Given this list of marker genes IL4I1, THAP4 (NCBI Gene Id 51078), ATP7A, HGD, TAT, HPD, SLC45A2 (NCBI Gene Id 51151), TTC36, IYD, FAH, DCT, TYR, PCBD1, GSTZ1, TH, PAH, OCA2, here is a description of the gene set: Human Gene Set: GOBP_TYROSINE_METABOLIC_PROCESS The chemical reactions and pathways involving tyrosine, an aromatic amino acid, 2-amino-3-(4-hydroxyphenyl)propanoic acid. studied in species Homo sapiens